The following is a description of a gene set: Peripheral arteriovenous fistula Human Gene Set: HP_PERIPHERAL_ARTERIOVENOUS_FISTULA studied in species Homo sapiens, and this is the list of marker genes: GDF2, RASA1, COL3A1, SMAD4, AGGF1, ACVRL1, EPHB4, ENG, PIK3CA